Given this list of marker genes Crls1, F7, Gclc (NCBI Gene Id 28039), Tomm70a, Abcb1a, Gclm, Ppp1r9b, here is a description of the gene set: Any process that results in a change in state or activity of a cell or an organism (in terms of movement, secretion, enzyme production, gene expression, etc.) as a result of a L-phenylalanine derivative stimulus. Mouse Gene Set: GOBP_RESPONSE_TO_L_PHENYLALANINE_DERIVATIVE species: Mus musculus